Given this list of marker genes Ncor2, Ep300, Tbl1x, Ncoa1, Gps2, Abca1, Hdac3, Rxrb, here is a description of the gene set: part of: NR1H2 and NR1H3-mediated signaling Reactome Pathway: NR1H3 & NR1H2 regulate gene expression linked to cholesterol transport and efflux This event has been computationally inferred from an event that has been demonstrated in another species.<p>The inference is based on the homology mapping from PANTHER. Briefly, reactions for which all involved PhysicalEntities (in input, output and catalyst) have a mapped orthologue/paralogue (for complexes at least 75% of components must have a mapping) are inferred to the other species. electronically inferred by orthology from the curated human pathway species: Mus musculus